The following is a description of a gene set: studied in species Mus musculus Mouse Gene Set: MIR_212_5P from publication Chen Y, Wang X (PMID 31504780) Genes predicted to be targets of miRBase v22 microRNA mmu_miR_212_5p in miRDB v6.0 with MirTarget v4 prediction scores > 80 (high confidence targets)., and this is the list of marker genes: Rhoq (ras homolog family member Q), Tle4, Sertad4, Pnma3, Stard7, Nfyc, F13a1, Ccdc117, Pafah1b2, Ralgds, Cldn2, Cacna1c, Chdh, Ctdsp2, Vat1, Ovol1, Sepsecs, Mex3c, Abtb3, Ak1, Ankrd28, Slc6a8, Myh9, Pik3c2b, Cul3, Dll1, D5Ertd579e, Rapgef3, Rapgef6, Slc25a1, Mamld1, Xpo6, Larp4, 1600012H06Rik, Cbln2, Slc48a1, Mpped2, Nr2c1, Slc1a4, Syt9, Usp47, Vps37d, Rasl10b, Slc12a6, Atg16l1, Akt3, Helz2, Phb1 (prohibitin 1), Tceanc2, Cobl, Irf2bpl, Plxna2, Itgav, Cnr1, Iqsec2, Dcaf12, Plxdc2, Ddx3x, Ddx3y, Maco1, Mfsd2a, Ubr1, Acy1, Egr3, Ttc22, Nudt11, Ano1, Scamp3, Ivns1abp, Krt26